The following is a description of a gene set: studied in species Homo sapiens The process that mediates interactions between an atrial cardiomyocyte and its surroundings that contributes to the process of the atrial cardiomyocyte communicating with an AV node cell in cardiac conduction. Encompasses interactions such as signaling or attachment between one cell and another cell, between a cell and an extracellular matrix, or between a cell and any other aspect of its environment. Human Gene Set: GOBP_ATRIAL_CARDIAC_MUSCLE_CELL_TO_AV_NODE_CELL_COMMUNICATION, and this is the list of marker genes: CACNB2, FLNA, MIR328, GJA1, SCN5A, KCNJ3, GJC1, RYR2, NUP155, SCN3B, CACNA1C, GJA5, ANK2 (ankyrin 2), KCNQ1, TRPM4, KCNA5 (potassium voltage-gated channel subfamily A member 5), KCNJ5, KCNN2, KCNE5